The following is a description of a gene set: Human Gene Set: GSE1460_NAIVE_CD4_TCELL_ADULT_BLOOD_VS_THYMIC_STROMAL_CELL_UP Subpopulations of human fetal thymocyte and circulating naïve T cells were obtained through FACS sorting, including CD3-CD4+CD8- intrathymic T progenitor cells (ITTP), CD3intCD4+CD8+ \double positive\ thymocytes (DP), CD3highCD4+CD8- \single positive\ thymocytes (SP4), CD3+CD4+CD8-CD45RA+CD62L+ naive T cells from cord blood (CB4+), and CD3+CD4+CD8-CD45RA+CD62L+ naive T cells from adult blood (AB4+). Genes up-regulated in naive CD4 T cells from adult blood versus thymic stromal cells. species: Homo sapiens from publication Lee MS, Hanspers K, Barker CS, Korn AP, McCune JM (PMID 15210650), and this is the list of marker genes: RFC1, RPL10L, SRSF5 (serine and arginine rich splicing factor 5), TXK, SLC43A1, TM7SF2, GCH1, RFX1, LEPROTL1 (leptin receptor overlapping transcript like 1), PIAS1, STK19, DIAPH1, TRIM26, EEF1G, BACH2, NFX1, GAP43, PI4KA, PRKCZ, IKZF1, USP4, CDK5RAP1, RPS13, MMP19, MEPCE, HPCAL1, SCYL3, SASH3, MSL2, TBC1D31, HSD17B7, CSNK1E, TH, H1-3, HPN, TAPBPL, SAFB, MLLT3, SPOCK2, ZNF174, MED9 (NCBI Gene Id 55090), RIPK1, POLD1, MAPK14, HTT, SLC26A1, GPR157, RPL10A, HEATR6, DAZAP2, CRLF3, TNFAIP8, CAB39L, IL21R, BTN3A1, PSTPIP1, COG2, RPL35, M6PR, CERK, SUPV3L1, KHK (ketohexokinase), ZNF862, COQ8A, CYP4F2, RADX, MARCHF6, ZNF665, MLC1 (NCBI Gene Id 654039), ZNF778, DNASE2, RPS15A, PBXIP1, MAT2A, NDE1, STAT6, AP3M2, CTRB2, DUSP13B, GAL3ST4, CUZD1, DDX5, HSPA1L, PCYOX1L, CCND3, CUL1, IRAG2, PDE4C, DCLRE1C, SNN, UBE2G2, INPP5D, DDX23, WWP1, POLR2B, MRFAP1L1, FGF6, CLEC2B, MEGF6, STARD3, TMEM179B, PRKACG, BIN2, ANAPC5, IGLV1-44, ANKRD36B, PCSK7, NSUN5P2, TMEM140, UBE2L3, ST3GAL5 (ST3 beta-galactoside alpha-2,3-sialyltransferase 5), ATP6V1G1, GSN-AS1, CBFB, PRG2, GUCA2B, VPS41, CENPO, ABCG5, TBX1, LPIN2, KRI1, IRF9, NHERF1, USP9X, C1QTNF3, SPN, GARRE1, TCIRG1, TRAT1, ADA2, ZNF446, IL4R, AAK1, HMCES, MMP15, LAMC3, FBXO46, HIRIP3, PYGM, TMEM59L, CLK4, GTF2H3, UTP6, MLN, ERICH1, ARHGEF18, SUV39H1, LST1, PCDHB13, KLK15, LETMD1, BRME1, NACA, FXYD1, RPS8, DELE1, PPIL2, NUP50, NCOA2, TSPYL2 (NCBI Gene Id 64061), LONP2, MMP28, USP7, FRAT2, ATP4A, CCDC33, KDM3A, SNRK, TAOK1, EP300, PIM1, CAB39, DDX50, ZNF3, BAP1, KRTAP5-8, LAGE3P1, TUBGCP4, EEF1B2, POLL, TPP1, GAL3ST1, CTC1, DEF6, NOP53, DPP8, FAM168B, TSC22D3, LRIG2, FOXO4, NACA2, SEC24C